The following is a description of a gene set: Genes up-regulated in liver from SOC3 knockout: untreated versus IL6 injection. Changes in mouse liver mRNA profiles following intraperitoneal cytokine injection. Either interferon-gamma-/-, albumin-cre(-) Socs3(w/fl) mice, or albumin-cre(+) Socs3(-/fl) mice were injected with either phosphate-buffered saline, interferon-gamma, or interfeukin-6, and livers taken after 4h. species: Homo sapiens Human Gene Set: GSE369_PRE_VS_POST_IL6_INJECTION_IFNG_KO_LIVER_UP from publication Croker BA, Krebs DL, Zhang JG, Wormald S, Willson TA, Stanley EG, Robb L, Greenhalgh CJ, Förster I, Clausen BE, Nicola NA, Metcalf D, Hilton DJ, Roberts AW, Alexander WS (PMID 12754505), and this is the list of marker genes: MYO1F, MTSS1 (NCBI Gene Id 9788), AFP, LYRM7, PTP4A3, FAM110D, METTL1, EIF4ENIF1, EPHX1, SDC1, PSMD13, ARRB1, STK11IP, SLAMF7, WWP2, GMEB1, TSPAN2, SPATA1, AP3S1, PDE1B, AHNAK, PTPN6, SFTPB, KLHDC4, HYAL4, PHYKPL, IL4R, MAP4K1, HSD11B1, CPM, ACOT9, APC, NR2C2AP, NOL12, SYNPO, H2AC25, GRK2, ANAPC15, CISD3, SFT2D1, TIGD3, FXYD5, AP3B1, IQUB, PLTP, RALGPS2, G6PD, DRG1, NOMO1, HAGHL, CDK11B, CECR2, QTRT1, IPO5 (importin 5), IBSP, CAD, HCLS1 (NCBI Gene Id 3059), POLR2K, ACTR2, NCF4, LIMK2, NEURL2, MRPS23, SPPL2A, TREX1 (NCBI Gene Id 82474), ANGEL2, SLAMF8, CORO2A, KLHDC9, RAI1, HACD2, USP29, LRP4, CDKN2AIPNL, EVI2B, STRADA, NECAP1, KRT10, WLS, GET4, HVCN1, RARB, DNAH8, RAP1B, SMAD1, EIF3C, LIAS, SLC10A4, ACOD1, DENND2B, ADGRE5, HSD17B12, C19orf48P, CTSA, TCTA, TRAPPC1, ARHGAP1, PSPC1, DPM3, EYA2, SERPING1, TMEM71, NFATC1, PLCG2 (phospholipase C gamma 2), PSENEN, CSRP2, AIRIM, RBBP8, NDUFB2, PARVG, NPPA, CD93, CORO1A, GPD1L, TNK2, MIS18A, INTS4, RYR1, FTX, FLII, PLEKHG2, MORF4L1, DNTTIP1, KCNAB1, PIK3CG, DEF6, DNMT1, UQCC2 (NCBI Gene Id 84300), CZIB, CA2, C7orf50, PRKCB, COL23A1, EPS8, TUFT1, HES6, PLEKHA2, LRP10, LRRC19, MAN2B1, AGO4, ERGIC3, SETD5, RP1, CNDP2, NXPE2, CD46, YTHDC2, WWC2, CRLF2, PPP1R10 (protein phosphatase 1 regulatory subunit 10), PTTG1, ZCCHC24, GABRA3, ADRM1, RFX1, HNF1A, NGFR, IDH3G (NCBI Gene Id 3421), LPP, MAP3K20, RBMS1, TRPT1 (tRNA phosphotransferase 1), FCGRT, PAK6, THOC3, PTGER4, LYL1, MARCHF7, RGS18, ARPC5, POLR3H (NCBI Gene Id 91605), CCKBR, LAD1, MAPK3, ARG1, MRPL58, CD200, EMP3, C1orf131, VPREB3, JPT1, RASA3 (RAS p21 protein activator 3), RHOA, MLLT6, APOB, PARP2, DGKG, SORL1, BMF, METTL23, PRDX1, FMNL3, GALNT6, VIPR1, TET3, PRSS12, MOB3B, ZNF354C, ETV5